Given this list of marker genes RPGR (NCBI Gene Id 6110), MAK, CNGB1, IMPG1, PCARE, RP1L1, TTC8, SLC7A14, IMPDH1, RP1, LRAT, PRPF4, PRPF3 (pre-mRNA processing factor 3), NR2E3, DHX38, PDE6B, ALMS1 (ALMS1 centrosome and basal body associated protein), BBS5, AGBL5, PRPF31, UNC45B, BBS2, FTL, DHDDS, OPA3, HGSNAT, SPRTN, TONSL, TUB, SEMA4A, BBS1, FAS, CLRN1, KIZ, CYP1B1, FZD4 (frizzled class receptor 4), NEK2, SPATA7, TULP1, AHR, CC2D2A, IFT88, ZNF408, NRL, ABHD12, FAM161A, CERKL, ARHGEF18, CA4, IDH3A (isocitrate dehydrogenase (NAD(+)) 3 catalytic subunit alpha), CHMP4B, IMPG2, SNRNP200, AHI1, PDE6A, POMGNT1, PROM1, PTPN22, RPE65 (retinoid isomerohydrolase RPE65), IFT140, TOPORS, CNGA1, IDH3B, ROM1, GUCA1B, KIAA1549, PRPF8 (NCBI Gene Id 6108), ZNF513, CRX, ARL2BP, PRPF6, CFAP410, RPGRIP1, SCAPER, RP2, PITX2, RDH12, CHM, FOXC1, MERTK, CNBP, PRCD, CDHR1, FSCN2, OAT (NCBI Gene Id 4942), LRP5, RLBP1, BEST1, ARL6 (ADP ribosylation factor like GTPase 6), POLR3GL, RP9, PAX6, PDE6G, ARL3, IFT172, PRPH2, RBP3, ADAMTS18, NF2, RGR, USH2A (NCBI Gene Id 7399), REEP6, CFAP418, WT1, LCA5, OFD1, ABCA4, EYS, ATP7B, XYLT2, GJA8, CRB1 (NCBI Gene Id 6107), KLHL7, FOXE3, ABHD5, SAG (S-antigen visual arrestin), RHO, here is a description of the gene set: A cataract that affects the region of the lens directly beneath the capsule of the lens. studied in species Homo sapiens Subcapsular cataract Human Gene Set: HP_SUBCAPSULAR_CATARACT